Given this list of marker genes RAB32, RAB39B, RAB1A, RAB3IP, TRAPPC10, TBC1D10B, RAB7A, RAB11B, GGA2, TBC1D16, TBC1D17, DENND5A, RAB3GAP2, RAB27B, RAB13, TRAPPC8, TRAPPC1, RAB33A, GABARAPL2, OPTN, TBC1D14, RAB4A, YWHAE, CCZ1, ALS2, HPS1, RAB6B (NCBI Gene Id 51560), MON1B, RAB3A, RIN1, RAB38, RAB31, ANKRD27, TRAPPC4 (NCBI Gene Id 51399), RAB9A, GAPVD1, RAB12, TBC1D10C, TBC1D3, DENND3, TRAPPC2, RABEP1, TRAPPC12, TBC1D2, TRAPPC3, DENND4C, AKT3, RAB35, DENND1B, DENND4B, RABGAP1, DENND2D, GGA3, DENND5B, TBC1D13, MADD, TBC1D24, RAB8A, RAB9B (RAB9B, member RAS oncogene family), RAB5B, RABGEF1, RAB5A, TRAPPC13, DENND1A, RAB7B, RAB21, RAB8B, TSC2, RGP1 (RGP1 homolog, RAB6A GEF complex partner 1), RIN2, RAB11A, HPS4, TRAPPC6A, DENND6A, CCZ1B, MON1A (MON1 homolog A, secretory trafficking associated), GABARAP, RAB1B, CHM, CHML, TRAPPC2L, RAB14, RAB18, RINL, RAB39A, TBC1D20, SYTL1, TRAPPC5, RAB5C, MAP1LC3B, AKT1, ARF6, DENND2A, TSC1, RIC1, ALS2CL, DENND6B, DENND4A, SBF1, GDI1, RAB33B, DENND2B, TBC1D7, TBC1D25, RAB27A, TRAPPC9, GDI2, DENND1C, SBF2, TBC1D15, TRAPPC11, DENND2C, ULK1 (unc-51 like autophagy activating kinase 1), TBC1D10A, RAB10, TRAPPC6B, RAB3GAP1, AKT2, RAB3IL1, RAB6A, RIN3, GGA1, here is a description of the gene set: studied in species Homo sapiens Human Gene Set: REACTOME_RAB_REGULATION_OF_TRAFFICKING Rab regulation of trafficking